The following is a description of a gene set: Negative regulation of FLT3 Human Gene Set: REACTOME_NEGATIVE_REGULATION_OF_FLT3 studied in species Homo sapiens, and this is the list of marker genes: CBL, SOCS2, UBC, FLT3LG, SOCS6, SH2B3, RPS27A, FLT3, SLA, CSK, UBA52, ABL2, SLA2, PTPRJ, UBB